The following is a description of a gene set: Mouse Gene Set: GOBP_RENAL_RESPONSE_TO_BLOOD_FLOW_INVOLVED_IN_CIRCULATORY_RENIN_ANGIOTENSIN_REGULATION_OF_SYSTEMIC_ARTERIAL_BLOOD_PRESSURE species: Mus musculus The physiological response of the kidneys to a decrease in blood flow., and this is the list of marker genes: F2rl1, F2r, Agt, Sucnr1, Comt, Ednrb, Gja5, Kcnn4, Agtr1a, Or51e2